The following is a description of a gene set: Identification of ROS induced genes on dendritic cells Dendritic cells were incubated for 15 min with or without a ROS inhibitor (DPI), washed extensively and incubated for 30 min with a chemical allergen (DNFB), hydrogen peroxide, and vehicle alone in HBSS containing DPI or vehicle. After washed extensively, the samples were post-incubated for 5.5 h with DNFB, hydrogen peroxide, or vehicle in complete culture medium containing DPI or vehicle. from publication Miyazawa M, Takashima A (PMID 22974541) Human Gene Set: GSE20727_DNFB_ALLERGEN_VS_ROS_INH_AND_DNFB_ALLERGEN_TREATED_DC_DN Genes down-regulated in dendritic cells: 2,4-dinitrofluorobenzene (DNFB) versus diphenyleneiodonium (DPI). species: Homo sapiens, and this is the list of marker genes: KCTD11, ZFPM1 (NCBI Gene Id 161884), NFATC1, GINS1, FAM72A, FURIN, APOBEC3B, UNC119B, CTSB, RDH12, NT5C2, SRI, LSM1, BRCA1, TMEM106A, EFHD2, NEK7, FAS, KIAA1191, TTK, FUNDC1, ZFAND4, PDCD1LG2, MAP2K3, LMAN1, CENPA, CPD, HIF1A, PRNP, PLEKHB2, TCEAL9, ART3, PSMC6, TIAM1, SKA1, BAIAP3, PCDHB10, RPA2, BORA, EMC10, UBXN2B, DHFR, POLD3, ALDH7A1 (aldehyde dehydrogenase 7 family member A1), PCLAF, LIME1, SYT6, TMEM158, ADPRH, STK39, TRPT1, NFATC2, DNASE1L3, HADHA, TMEM62, TSPAN3 (tetraspanin 3), ARL6, RFX5, FOXM1, CKAP5, NEURL1B, METTL15, GZMK, MATK, NAT1, NDUFS3, CYP11A1, SRXN1, PKN3, PLK4, SHCBP1, HIP1R (NCBI Gene Id 9026), HROB, LACC1, PXMP2, CENPH, GTSE1, STON2, PTGR2, COX7A2, FAM20A, ZNRD2, COX8A, HES5, MELK, CIP2A, GNE, NAPRT, TMEM11, RGS10, RORA, PML, XRCC6, SERPINF1, ESCO2, DHRS1, MGARP, FLNB, MRPL34, FBXW8, MCM10 (NCBI Gene Id 55388), TRIP13, FGL2, MRPL54, RHOD, UBXN8, PERP, VCPKMT, BCAT1, CARNMT1, PPP3CC, SIVA1, COQ3, ADIPOR2, GEN1, PDYN, EI24, PCDHGC4, DSCC1, ERLIN1, TSPAN5, DGKH (diacylglycerol kinase eta), IL18R1, CCDC92, ROPN1L, FYN, RTF2, SNRPC, NUSAP1, ZEB2, TTC16, TRMT1L, TUBB3, ECT2 (epithelial cell transforming 2), UHRF1, CDC6, SPC25, VSIG10, NDRG4, C9orf152, ABHD4, DNA2, MAFG, PRELID2, CARHSP1, SPRY1, KIF20A, IFT52, SALL1, PLXDC1, CCNF, CDK4, ABI2, DTL, DYNLT1, AHCY, RNH1, NINJ2, XK, GINS2, CKAP2, CLPB, CAPNS1, ABR, TRPS1, PBK, SLC43A1, WEE1, MNS1, PLXDC2, ISG20, TPI1, CEBPA, POMP, MND1, SRGN, COBLL1, KIF2C, LRP1 (NCBI Gene Id 4035), SLC16A3, SYTL3, FAM81A, SCCPDH, NMRAL1, ELK3, EHBP1L1, XAF1, ARHGAP19, DHRS7, PEAR1, TKFC (NCBI Gene Id 26007), CLIP2, ATF6, SMPDL3A, MORN1, CENPK, MANSC1, BHLHE40, BRI3BP